The following is a description of a gene set: species: Homo sapiens Genes up-regulated in response to nutlin-3a, an inhibitor of MDM2, in skin fibroblast cultures after knockdown of TP53 by RNAi. from publication Kumamoto K, Spillare EA, Fujita K, Horikawa I, Yamashita T, Appella E, Nagashima M, Takenoshita S, Yokota J, Harris CC (PMID 18451145) Human Gene Set: KUMAMOTO_RESPONSE_TO_NUTLIN_3A_UP Nutlin-3, an MDM2 inhibitor, activates p53, resulting in several types of cancer cells undergoing apoptosis. Although p53 is mutated or deleted in approximately 50% of all cancers, p53 is still functionally active in the other 50%. Consequently, nutlin-3 and similar drugs could be candidates for neoadjuvant therapy in cancers with a functional p53. Cellular senescence is also a phenotype induced by p53 activation and plays a critical role in protecting against tumor development. In this report, we found that nutlin-3a can induce senescence in normal human fibroblasts. Nutlin-3a activated and repressed a large number of p53-dependent genes, including those encoding microRNAs. mir-34a, mir-34b, and mir-34c, which have recently been shown to be downstream effectors of p53-mediated senescence, were up-regulated, and inhibitor of growth 2 (ING2) expression was suppressed by nutlin-3a treatment. Two candidates for a p53-DNA binding consensus sequence were found in the ING2 promoter regulatory region; thus, we performed chromatin immunoprecipitation and electrophoretic mobility shift assays and confirmed p53 binding directly to those sites. In addition, the luciferase activity of a construct containing the ING2 regulatory region was repressed after p53 activation. Antisense knockdown of ING2 induces p53-independent senescence, whereas overexpression of ING2 induces p53-dependent senescence. Taken together, we conclude that nutlin-3a induces senescence through p53 activation in normal human fibroblasts, and p53-mediated mir34a, mir34b, and mir34c up-regulation and ING2 down-regulation may be involved in the senescence pathway., and this is the list of marker genes: SULF2, GDF15, BTG2, MDM2, PLTP, TP53I3, SESN1, CYFIP2, NINJ1